Given this list of marker genes Gm5740, Hand2, Galntl6, Glra3 (glycine receptor, alpha 3 subunit), Gm34370 (NCBI Gene Id 102637603), Gm25379, 2500002B13Rik, Gm15881, Adam29, Gm7419 (predicted gene 7419), Cep44, AW046200, Sap30, Hand2os1, Gm19269, Fbxo8, Gm7328, Hpgd, Gm7351, Gm7499, Gm24375, Gm6012, Hmgb2, 4930412F12Rik, Gm2767, Hdnr, Gm34030, Galnt7, Gm33501, Gm6503, 4930518J21Rik, Gm17994 (NCBI Gene Id 100416239), Gm10284, Scrg1, BC030500, here is a description of the gene set: Mouse Gene Set: chr8B2 studied in species Mus musculus